The following is a description of a gene set: Human Gene Set: GOMF_UBIQUITIN_LIGASE_COMPLEX_SCAFFOLD_ACTIVITY The binding activity of a molecule that brings together an ubiquitin ligase and an ubiquitin ligase-substrate adaptor, permitting those molecules to function in a coordinated way. studied in species Homo sapiens, and this is the list of marker genes: DDB1, CUL3, CUL7, CUL2, CUL5, SKP1, CUL4A, CUL1